Given this list of marker genes Prom1, Dscam, Samd11, Rp1, Slc4a7, Nrl, Cntf, Mir124a-1, Dio3, Crb2, Bbs10, Ptn, Sox8, Mir182, Gnat2, Bbs4, Alms1, Hcn1, Sdk2, Ntrk2, Rom1, Pde6c, Ndp, Thy1, Ihh, Mir183, Samd7, Sox9, Bhlhe23, Naglu, Rpgrip1, Trpm1, Vax2os, Notch1, Cabp4, Stat3, Thrb, Ush1c, Cfh, Mir96, Cnga3, Rorb (NCBI Gene Id 225998, RAR-related orphan receptor beta), Ahi1, Miat, Mir124a-2, Casz1, Gnat1, Rpgrip1l, Ttc8, here is a description of the gene set: The process in which a relatively unspecialized cell acquires the specialized features of a photoreceptor cell in a camera-type eye. species: Mus musculus Mouse Gene Set: GOBP_CAMERA_TYPE_EYE_PHOTORECEPTOR_CELL_DIFFERENTIATION